The following is a description of a gene set: species: Homo sapiens Dysregulated Notch signaling contributes to breast cancer development and progression, but validated tools to measure the level of Notch signaling in breast cancer subtypes and in response to systemic therapy are largely lacking. A transcriptomic signature of Notch signaling would be warranted, for example to monitor the effects of future Notch-targeting therapies and to learn whether altered Notch signaling is an off-target effect of current breast cancer therapies. In this report, we have established such a classifier, a 20-gene transcriptional signature. To generate the signature, we first identified Notch-regulated genes from six basal-like breast cancer cell lines subjected to elevated or reduced Notch signaling by culturing on immobilized Notch ligand Jagged1 or blockade of Notch by γ-secretase inhibitors, respectively. From this cadre of Notch-regulated genes, we developed candidate transcriptomic signatures that were trained on a breast cancer patient dataset (the TCGA-BRCA cohort) and a broader breast cancer cell line cohort and sought to validate in independent datasets. An optimal 20-gene transcriptomic signature was selected. We validated the signature on two independent patient datasets (METABRIC and Oslo2), and it showed an improved coherence score and tumor specificity compared with previously published signatures. Furthermore, the signature score was particularly high for basal-like breast cancer, indicating an enhanced level of Notch signaling in this subtype. The signature score was increased after neoadjuvant treatment in the PROMIX and BEAUTY patient cohorts, and a lower signature score generally correlated with better clinical outcome. The signature will be a valuable tool to evaluate the response of future Notch-targeting therapies for breast cancer, to learn about potential effects on Notch signaling from conventional breast cancer therapies and to better stratify patients for therapy considerations. Human Gene Set: BRAUNE_GEIST_20_GENE_NOTCH_SIG_BREAST_CANCER from publication Braune EB, Geist F, Tang X, Kalari K, Boughey J, Wang L, Leon-Ferre RA, D'Assoro AB, Ingle JN, Goetz MP, Kreis J, Wang K, Foukakis T, Seshire A, Wienke D, Lendahl U (PMID 38172915) Notch transcriptomic signature as a tool to measure the level of Notch signaling in breast cancer, and this is the list of marker genes: MT1X, KIT, PLAT, HEY1, HEY2, FLT1, KRT14, NPR3, SEMA5B, FAT2, TNFRSF19, RHOV, VSNL1, PRELP, HEYL, KRT5, PDGFRB, NRARP, JAG1, ZNF469